The following is a description of a gene set: This event has been computationally inferred from an event that has been demonstrated in another species.<p>The inference is based on the homology mapping from PANTHER. Briefly, reactions for which all involved PhysicalEntities (in input, output and catalyst) have a mapped orthologue/paralogue (for complexes at least 75% of components must have a mapping) are inferred to the other species. part of: HDR through Homologous Recombination (HRR) electronically inferred by orthology from the curated human pathway studied in species Mus musculus Reactome Pathway: Homologous DNA Pairing and Strand Exchange, and this is the list of marker genes: Wrn, Brca1, Kat5 (NCBI Gene Id 81601), Nbn, Xrcc3, Rad51b, Brca2, Rbbp8, Top3a, Blm, Mre11a, Bard1, Rad51ap1, Dna2, Rad51c, Palb2